The following is a description of a gene set: species: Mus musculus A lipoprotein particle, rich in cholesterol esters and low in triglycerides that is typically composed of APOB100 and APOE and has a density of 1.02-1.06 g/ml and a diameter of between 20-25 nm. LDL particles are formed from VLDL particles (via IDL) by the loss of triglyceride and gain of cholesterol ester. They transport endogenous cholesterol (and to some extent triglycerides) from peripheral tissues back to the liver. Mouse Gene Set: GOCC_LOW_DENSITY_LIPOPROTEIN_PARTICLE, and this is the list of marker genes: Ldlr, Apobr, Lsr, Apoc2l, Selenos, Apoa1, Apob, Apoa4, Apom, Pla2g7, Apoe, Msr1, App, Apoc2, Apof